The following is a description of a gene set: studied in species Mus musculus A type of endosome in which regions of the limiting endosomal membrane invaginate to form internal vesicles; membrane proteins that enter the internal vesicles are sequestered from the cytoplasm. Mouse Gene Set: GOCC_MULTIVESICULAR_BODY, and this is the list of marker genes: Chmp7, Tpt1, Sftpb, Pmel, Chmp1b, Chmp5, Rab27b (RAB27B, member RAS oncogene family), Slc17a8, Ctsl, Chmp4c (NCBI Gene Id 74324), Tmem9, Slc2a4, Hgs, Acp3, Sftpd, Prkar1a, Mbl1, Atp13a2, Cd300lg, Nsg2, Crhbp, Chmp1a, Crhr1, Prkar1b, Chmp3, Sftpc, Abcb6, Gimap5, Nedd4l, H2-Ab1 (NCBI Gene Id 406212), Lamp1, Cst7, Lrrk2, Slc9a8, Apoe, Steap3, Chmp6, Vta1, H2-DMb2, Rab27a (RAB27A, member RAS oncogene family), Ecpas, Sftpa1, Nsg1, Cd63, Bst2, Abca3, Chmp1b2 (NCBI Gene Id 74520), Mbl2, Gfra1, Arap1, Rab11a, Egfr, Gja1, Bace1, Sorl1, Chmp2b, Chmp4b, Lrat (lecithin-retinol acyltransferase (phosphatidylcholine-retinol-O-acyltransferase)), Cst3, H2-DMa, Laptm4b, Zp2, Chmp2a, Cd79a, Cd74